The following is a description of a gene set: Human Gene Set: GOBP_REGULATION_OF_GLUTAMATE_SECRETION species: Homo sapiens Any process that modulates the frequency, rate or extent of the controlled release of glutamate., and this is the list of marker genes: ADORA1, SYT4, NPY5R, TRH, GRM2, NTSR1, RAB3GAP1, P2RX7, KMO, PRKG1, STXBP1, SLC38A2, GRM7, ADORA2A, DTNBP1, AVP, AVPR1A, GABBR1, SNCA